Given this list of marker genes WDSUB1 (NCBI Gene Id 151525), SCN3B, UBE2L6, PGAP6, C11orf68, APH1B, INPP4A, GABBR1, TPPP3, SIPA1L3, CWH43, WDR81, NAIF1, ROGDI, NCKIPSD, GNG2, FZD7, SLC12A9, POLB, LMO2, SLC66A1, MYO9A, RTL5, RNF217, SLC5A1, TRIM7, C1orf198 (NCBI Gene Id 84886), ZNRF4, MFSD12, PPT1, NCF1 (NCBI Gene Id 653844), VWA1, MYBPC3, CCL22, SERPINB2, NUAK2, RASSF3, NPC2, EXOC6B, PAK4, TRIP6, ADCK1, REEP3, KRT35, TSEN34, RPS6KA2, AVPI1, PPFIBP2, MAP3K12, SULT1E1 (sulfotransferase family 1E member 1), SLC15A1, COL6A2, GLI1, GCOM1 (NCBI Gene Id 145781), GNG12, PRG4, MAPK7, HAGH, IFT140, LPAR3, ZNF23, COL1A1, KCNK6, MTMR10, CDS1, TSPAN17, PDP2, STIMATE, PLD4, SOX12, ITPRIPL1, DUSP1, BOK, PSTPIP2 (proline-serine-threonine phosphatase interacting protein 2), ECE1, CD1D, SSC4D, GARIN1B, BCL11A, TEP1, ABCA13, CDKN2B, CHST15, NAAA (N-acylethanolamine acid amidase), PKD1, ZNF839, FCGR3A, CD68, SH3PXD2B, OCSTAMP, GNB4, KCTD16, ZUP1, ARID4A, ARMCX6, RNF214, IFIH1, LIPA (NCBI Gene Id 3988), TRAPPC1, CREB3, CMTM6, STARD3, RDH5, STXBP3, ELAPOR2, VAV2, ST6GAL1, LPAR6, SEL1L, TMPRSS4, NOSTRIN, ATOSB, LRCH1, FADS2, TMEM132A, NEUROD4, DDX4, CYB5A, ST3GAL5, ATP6V1D, AHRR, WDFY4, UBC, PLCL1, IFITM2, TWF1, TSPOAP1, SEC14L5, MARCKSL1 (MARCKS like 1), CCDC90B, ZC2HC1A, RAB39A, CC2D2B, SCN2B (sodium voltage-gated channel beta subunit 2), ADAP2, CD2AP, RAB11FIP1, TAX1BP3, KIFAP3, ZNF710, WNT8A, C3orf70, PNMT, ALS2, OLFM1, TNFRSF21 (TNF receptor superfamily member 21), ZNF467, SHROOM1, HMGN3, CLDN15, NAGA, SLC15A4, RARG, PLXDC1, JARID2, ANXA7, C6orf132, PRKAB2, ATMIN, ADAMTS15, DBN1, CKB, CDC42BPG, OGFRL1 (opioid growth factor receptor like 1), SLC29A3, ARC, RSAD2, NUDT17, GOT2, SPI1, KBTBD12, SMAGP, ANKRD1 (ankyrin repeat domain 1), RUFY3, SH3BGRL, CDC42BPB, CRIPTO, FER1L4, VPS9D1, NXPH3, CCDC24, WDFY3, PLEKHM3, SLC25A20, BMP2K, APOBR, PPP1R14A, CALHM6, FAM184B, PIGF, DDX17 (NCBI Gene Id 10521), KIAA0232, GPR35, THRB, FNIP2, RASA4, MAN2C1, P2RX6, MATCAP1, TMEM51, here is a description of the gene set: Genes up-regulated in marginal zone B cells versus day 40 memory B cells. from publication Kaji T, Ishige A, Hikida M, Taka J, Hijikata A, Kubo M, Nagashima T, Takahashi Y, Kurosaki T, Okada M, Ohara O, Rajewsky K, Takemori T (PMID 23027924) Human Gene Set: GSE11961_MARGINAL_ZONE_BCELL_VS_MEMORY_BCELL_DAY40_UP studied in species Homo sapiens To obtain insight into the genetic basis of the increase of functional activity of memory B cells over time, we compared the gene expression profiles of day 7 and day 40 NP-specific/IgG1 memory B cells, GC B cells and plasma cells in immunized WT mice and naïve B cells, before and after activation in vitro.